The following is a description of a gene set: species: Homo sapiens Genes from the recurrent amplicons in 89 samples of oral squamous cell carcinoma (SCC). Genomes of solid tumors are characterized by gains and losses of regions, which may contribute to tumorigenesis by altering gene expression. Often the aberrations are extensive, encompassing whole chromosome arms, which makes identification of candidate genes in these regions difficult. Here, we focused on narrow regions of gene amplification to facilitate identification of genetic pathways important in oral squamous cell carcinoma (SCC) development. We used array comparative genomic hybridization (array CGH) to define minimum common amplified regions and then used expression analysis to identify candidate driver genes in amplicons that spanned <3 Mb. We found genes involved in integrin signaling (TLN1), survival (YAP1, BIRC2), and adhesion and migration (TLN1, LAMA3, MMP7), as well as members of the hedgehog (GLI2) and notch (JAG1, RBPSUH, FJX1) pathways to be amplified and overexpressed. Deregulation of these and other members of the hedgehog and notch pathways (HHIP, SMO, DLL1, NOTCH4) implicates deregulation of developmental and differentiation pathways, cell fate misspecification, in oral SCC development. Human Gene Set: SNIJDERS_AMPLIFIED_IN_HEAD_AND_NECK_TUMORS from publication Snijders AM, Schmidt BL, Fridlyand J, Dekker N, Pinkel D, Jordan RC, Albertson DG (PMID 15824737), and this is the list of marker genes: FZD1, MMP7, RBPJ, CTTN, FGFR1, KDM4C, BAG4 (NCBI Gene Id 9530), PTPRR, TRAF6 (NCBI Gene Id 7189), EYS, RAD1, EGFR, UHRF2, STIM2, PTP4A1, MAPK8IP1, GLI2, PAK1, TACC1 (NCBI Gene Id 6867), SKP2, PTPRD, CCND1, CDK6, FGF3, LAMA3, PHF21A, BIRC2, TM4SF1 (NCBI Gene Id 9004), TLN1, BIRC3, ADAM9 (NCBI Gene Id 8754), YAP1, CD44, IL7R (NCBI Gene Id 3575), JAG1, MDM2, FJX1